The following is a description of a gene set: studied in species Mus musculus Mouse Gene Set: GOBP_MUSCLE_CELL_DEVELOPMENT The process whose specific outcome is the progression of a muscle cell over time, from its formation to the mature structure. Muscle cell development does not include the steps involved in committing an unspecified cell to the muscle cell fate., and this is the list of marker genes: Tbx3, Dyrk1a, Dcaf8, Mylk3, Mybpc2, Hottip, Bmp10, Trip10, Mef2c, Hey2, Lmod3, Norad, Myh10, Slc25a4, Ryr1, Igf1, Ednra, Smad6, Myoz2, Cavin4, Myom1, Tbx5 (T-box 5), Nrap, Tmtc3, Lrrc10, Pmp22, Meis1, Mef2a, Agtr2, Tomm70a, G6pd2, Flii, Tmod4, Six1, Cacnb4, Prickle1, Sdc1, Wdr1, Sgcb, Afg3l2, Mir499, Ldb3, Myof, Tnnt2, Prkar1a, Ccn4, Edn1, Cntnap2, Alpk3 (NCBI Gene Id 269957), Adra1b, Homer1, Casq1, Tbx18, Kdm1a, Itgb1, Bin1, Ramp2, Pin1rt1, Mybpc3, Myh11, Cflar, Bmpr1a, Selenon, Adm, Pi16, Ppara, Acta1, Akap6, Eng, Map2k4, Col14a1, Tpm1, Comp, Lmna, Tcap, Hdac9, Actn1, Wnt10b, Pdgfrb, Hdac4, Actg1, Pak1, Atp2a2, Zmpste24, Isl1, Atg7, Asb2, Uchl1, Parp2, Hdac5, Hamp2, Prkd1, Csrp3, Krt8 (keratin 8), P2rx2, Myod1, Maml1, Ppp3ca, Wfikkn2, Actn4, Six4, Zfp418, Megf10, Neb, Smo, Ttn, Atg5, Actn2, Srf, Mfn2, Myh6, Nfatc3, Fer1l5, Flnc, Ep300, Sorbs2, Large1, Casq2, Fdps, Synpo2l, Adra1a, Spg11, Cxadr, Bmp4, Yy1, Mypn, Dysf, Gata4, Nfatc2, Hamp, Cav3, Prkg1, Dicer1 (dicer 1, ribonuclease type III), Naglu, Mir208b, Pgm5, Ptcd2, Speg, Slc8a1, Ctcf, Myl2, Myf5, Lmod1 (leiomodin 1 (smooth muscle)), Ski, Bin3, Klhl40, Dner, Foxp1, Stac3, Ankrd23, Cacna1s, Sirt1, Myog, Rgs4, Fbxo22, Mybpc1, Nr3c1, Nkx2-5, Ppp3cb, Bves, Actn3, Kel, Tmod3, Camk2d, Ddx39b, Ctdp1, Chrnb1, Dmd, Cfl2, Col6a1, Alpk2, Smad4, Cdk1, Met, Xk, Akap13, Tnnt1, Myorg, Rgs2, Pin1, Capn3, Myoz1 (myozenin 1), Bcl2, Sypl2, Xirp1, Klhl41, Pdlim5, G6pdx (glucose-6-phosphate dehydrogenase X-linked), Rcan1, Mir208a, Cntnap1, Cacna2d2, Trim63, Gsk3b, Plec, Lncpint, Pitx2, Gsk3a, Myom3, Agt, Krt19, Csrp2, Fhod3, Actc1, Myo18b, Smyd3, Lox, Cav2, Fhl2, Neurl2, Myhas, Notch1, Hnrnpu, Hdac2, Myocd, Adprhl1, Ank2 (NCBI Gene Id 99906), Adrb1, Mybph, Prox1, Tmem182, Tmod2, Myom2, Mir351, Rbm10, Pbrm1, Shox2, Tnnt3, Vegfa, Myl9, Pdgfra, Efemp2, Ang2, Mtor, Nebl, Csrp1, Tmod1, Lmod2, Sgcd, Myf6, Wfikkn1, Nfatc4, Nkx2-6, Gpx1 (glutathione peroxidase 1), Hes1, Popdc2